The following is a description of a gene set: Genes predicted to be targets of miRBase v22 microRNA mmu_miR_1938 in miRDB v6.0 with MirTarget v4 prediction scores > 80 (high confidence targets). from publication Chen Y, Wang X (PMID 31504780) Mouse Gene Set: MIR_1938 studied in species Mus musculus, and this is the list of marker genes: Mpg, Zfp958, Dlx5, Hvcn1, Dtna, Taf15, Serpinb9, Bahcc1, Cbx7, Jph4, Spon2, Phip, Edar, Castor2, Cdh4, Dgkb, Zfp1005, Amph, Stk35, Zfp467, Id2, Mllt6, Gpr158, Iqsec2, Mlec, Cux1, Slc26a5, Klhl4, Ranbp10, Sin3a, Plagl2, Myef2, Map3k13, Lrrfip1, Maz, Pcmtd1, Meox1, Tnrc6a, Samd4b, Crisp1, Laptm5, R3hdm2 (R3H domain containing 2), Crisp3, Kdm4b, Mif4gd, Slc19a3, Cd300lb (CD300 molecule like family member B), Fam53c, Fancg, Iffo2, Rpl14, Zfp442, Tbpl1, Pbp2, Pbx3, Chd3, Or5d38, Nkx3-1, Gpr101, Brca1, Insyn2b, 7530416G11Rik, Pou2f1, Rhbdd1, Zfp345, Txnl4b, Fbxw2, Lrrc8e, Rtf1, Tent5b, Adcy1, Wdtc1, Mtcl2, Cav1, Zfhx2